The following is a description of a gene set: studied in species Homo sapiens Enables the energy-independent facilitated diffusion of a sodium ion through a transmembrane aqueous pore or channel. Human Gene Set: GOMF_SODIUM_CHANNEL_ACTIVITY, and this is the list of marker genes: PTPN3, FGF12, FGF11, SCN10A, FGF13, SCN7A, FXYD2, SCN5A, HCN2, TRPV3, CNGB1, ASIC4, CNGA1, GRIK4, SCNN1A, SGK1, FXYD1, SCN1B, FXYD4, HCN3, RANGRF, GRIN1, SCN4B, ASIC5, TMEM168, TRPM4, CAV3, CNGA3, SGK2, YWHAH, SLC4A11, FXYD7, TPCN1, SCN2A, KCNK3 (potassium two pore domain channel subfamily K member 3), TMPRSS3, KCNK9, SHROOM2 (NCBI Gene Id 357), MCOLN3, MCOLN1, SCN1A, RSC1A1, SCLT1, SCN4A, SCN11A, FXYD5, SCN2B, HCN4, PCSK9, ASIC3 (NCBI Gene Id 9311), ASIC1, FXYD6, NEDD4L, NOS1, HCN1, PKD2, SNTA1, C8orf44-SGK3, P2RX7, SCN3A, TRPM2, CAMK2D, NEDD4, SCN9A (sodium voltage-gated channel alpha subunit 9), GRIK5, KCNK1, SGK3, FXYD3, GLRX, GRIK1, TRPM5, GRIK3, GPLD1, FGF14, NALCN, GPD1L, ATP2B4, TPCN2 (NCBI Gene Id 219931), SCNN1D, ANK3, SCN8A, GRIK2, PKP2, FXYD6P3, AGT, COMMD1, SCNN1G, PKD2L1, ASIC2, SCN3B, SCNN1B